The following is a description of a gene set: studied in species Mus musculus Mouse Gene Set: GOBP_REGULATION_OF_PROTEIN_LOCALIZATION_TO_ENDOPLASMIC_RETICULUM Any process that modulates the frequency, rate or extent of protein localization to endoplasmic reticulum., and this is the list of marker genes: Akt1, Naca, Rtn4, Ddrgk1, Btf3